The following is a description of a gene set: Human Gene Set: GAVISH_3CA_METAPROGRAM_B_CELLS_PLASMA Genes upregulated in subsets of cells of a given type within various tumors In this study, an extensive analysis was conducted to define meta-programs (MPs) capturing intra-tumor heterogeneity across a spectrum of tumor types. The approach utilized non-negative matrix factorization (NMF) to analyze each cell type separately within individual tumor samples. This involved the analysis of malignant cells, macrophages, fibroblasts, endothelial cells, epithelial cells, T-cells, and B-cells. NMF was executed with varying parameter values (K=4, 5, 6, 7, 8, 9), thereby generating 39 programs for each cell type per sample. Each NMF program was summarized by the top genes based on NMF coefficients.\nRobust MPs were then delineated for each cell type using a set of stringent criteria, including recurrence within the same tumor, similarity to programs in other tumors, and non-redundancy within a tumor. Subsequently, these robust NMF programs were clustered (per cell type) based on Jaccard similarity, leading to the identification of MPs associated with each cell type.\nTo enhance the quality of the MPs, a refinement steps were undertaken, involving the removal of MPs suspected of reflecting low-quality data (with an overrepresentation of ribosomal proteins or mitochondrial-encoded genes), single-study inclusion, or similarity to miss-annotated cell types. studied in species Homo sapiens from publication Gavish A, Tyler M, Greenwald AC, Hoefflin R, Simkin D, Tschernichovsky R, Galili Darnell N, Somech E, Barbolin C, Antman T, Kovarsky D, Barrett T, Gonzalez Castro LN, Halder D, Chanoch-Myers R, Laffy J, Mints M, Wider A, Tal R, Spitzer A, Hara T, Raitses-Gurevich M, Stossel C, Golan T, Tirosh A, Suvà ML, Puram SV, Tirosh I (PMID 37258682), and this is the list of marker genes: MANF, TMEM258, CRELD2, SELENOS, PDIA4, HERPUD1, MYDGF, RABAC1, KRTCAP2, XBP1, DNAJB9, SEC61B, SEC11C, IGHG3, IGHA1, PPIB, IGLC2, LMAN1, PIM2, SDF2L1, MZB1, IGKC, NUCB2, PRDX4, ERLEC1 (endoplasmic reticulum lectin 1), PDIA6, SPCS3, SDC1, CD63, FKBP11, IGHA2, IGHG1, JCHAIN, SSR3, HSPA5, SSR4, TMEM59, SPCS1, TNFRSF17, IGHGP, IGLC3, HSP90B1, DERL3, RPN2, ITM2C, FKBP2, IGHG4, P4HB, IGHG2, SPCS2